Given this list of marker genes Slc36a3, Slc45a2, Slc2a4, Ctns, Slc15a4, Slc15a1, Slc25a18, Slc46a1, Slc16a1, Slc11a2, Slc45a4, Slc45a3, Slc36a1 (NCBI Gene Id 76010), Slc2a13, Slc15a2, Slc25a3 (NCBI Gene Id 68101), Slc25a22, Slc16a3, Slc36a2, Slc45a1, here is a description of the gene set: Enables the transfer of a solute or solutes from one side of a membrane to the other according to the reaction: solute(out) + H+(out) = solute(in) + H+(in). Mouse Gene Set: GOMF_SOLUTE_PROTON_SYMPORTER_ACTIVITY species: Mus musculus